Given this list of marker genes SLC39A13, ANKH, KDM6A, ADAMTS3, ANAPC1, WNT10A, PTH1R, PRKACB, SOX11, PIGL, CILK1, DSP (NCBI Gene Id 202512), ARID1B, CCDC8, CHD7, ERCC4, UBR1, DMP1, SEMA3E, ZMPSTE24, NPHS1, VARS1, OCRL, ZBTB7A, RAI1, TRIP11, CAMK2B, TONSL, NSD2, SBDS, POLR3B, FGD1, SPECC1L, ANTXR1, HOXD13, SMC3, SLC13A5, TEKT3, WNT5A, FAM20C, CDH1, TP63, DEAF1, NECTIN1 (nectin cell adhesion molecule 1), KRT6A, KRT6B, DPF2, CHST3, DLX4, ROR2, FOSL2, FAM20A, PAX9, DNAJC21, NDUFB11, CYP27B1, HDAC4, C2CD3, EHMT1, COBLL1, WDR26, HDAC8, TNFRSF11A, SMARCB1 (NCBI Gene Id 6598), SATB1, NFIX (nuclear factor I X), TBC1D24, JUP (junction plakoglobin), TWIST2, DNA2, SMARCE1, ARHGAP29, ADNP, RIC1, VDR, SFRP4, TCIRG1, IDS, GNAS, ATP6V1B2, PUS7, MSX1 (msh homeobox 1), FLNA, EDA, PRKAR1A, MKS1, GTF2H5, KRT17, CA2, ENPP1, CUL7, ARID1A, EDARADD, MIA3, BMP4, CPLX1, AMMECR1, ARID2, AMER1, INTU, CYP2R1, POLR3A, ACP5, KMT2D, FLNB, WNT10B, KAT6B, CCBE1, MAP3K7, P4HB, GJA1, LEMD2, SLC29A3, ERCC6, MMP2, PDGFRA, KCNJ2, DLG1 (NCBI Gene Id 1739), PAPPA2, SNX10, SLC37A4 (solute carrier family 37 member 4), EDNRA, AXIN2, IRF6, KDF1, NELFA, ELMO2, THRA, BCL11B, LIG4, DVL1, ATP6V0A2, IKBKG, MYSM1, TRIO, SEC23A, KMT2C, PIGA, PDE4D, DHCR7, NSD1, SMARCA4, CTBP1, CTSK, PTHLH, SUOX, CRTAP, EVC2, ARHGEF38, ZEB2, LETM1, ARSB, ERCC1, RHOA, TRPS1, KCNH1, ZFX, STX16, RAB23, PTCH1, FGF3, MID1, SMARCD1 (NCBI Gene Id 6602), ERCC8, FAM111A, EP300, KRT16, TGFA, KCTD1, NSUN2, LMNA, CREBBP, DPH1, RECQL4, DYNC2LI1, SEC24D, SUMO1, PIK3R1, KCNJ5, RAD21, SMARCC2, GLI3, GHR, CEP120, SMCHD1, SNX14, SRCAP (Snf2 related CREBBP activator protein), PRKACA, GLI1, INSR, ADAMTSL1, DPYD, KIF7, GNB2 (NCBI Gene Id 96628), RPS6KA3, NEK1, RUNX2, EDA2R, RECQL, TNFSF11, SP7, STAT3, SETBP1, IQSEC2, FAT4, GRHL2, TGFB1, PIGG, PIGF, SOX4, LONP1, GDF5, SH3PXD2B (SH3 and PX domains 2B), BRD4, APC2, IGF1, CHD6, APC, ABCA5, FGFR1, OBSL1, SLC1A2, EFL1, CLCN7, PDGFRB, TAF6, BCOR (NCBI Gene Id 57686), IL6ST, PORCN, TCF4, CBFB, ZSWIM6, SH3BP2, SMC1A (NCBI Gene Id 8243), TFAP2B, FLII, IFIH1, FGFR2, NAA10, LRP6, EVC, CDH11 (NCBI Gene Id 1009), IL11RA, NIPBL, here is a description of the gene set: studied in species Homo sapiens Human Gene Set: HP_ABNORMALITY_OF_DENTAL_ERUPTION An abnormality of tooth eruption. Abnormality of dental eruption